Given this list of marker genes Pgr, Sumo1, Nr1h3, Pias2, Esr1, Vdr, Nr1i2, Pias4, Rxra, Ube2i, Thrb, Pias3, Ppara, Nr3c1 (nuclear receptor subfamily 3, group C, member 1), Nr3c2, Nr5a2, Rara, Pias1, Hdac4, Rora, Ar, Nr1h2, Nr1h4, Sumo3, Thra, Nr5a1, Sumo2, here is a description of the gene set: Mouse Gene Set: REACTOME_SUMOYLATION_OF_INTRACELLULAR_RECEPTORS SUMOylation of intracellular receptors species: Mus musculus